Given this list of marker genes KLF4 (KLF transcription factor 4), KLF9, RB1, CDH1, STRAP, SP1, FOXA2, FOXP2, ARID1A, FOXJ2, TFAP2A, ZEB2, here is a description of the gene set: Reactome Pathway: Positive Regulation of CDH1 Gene Transcription <p>Numerous transcription factors have been identified as direct positive regulators of transcription of CDH1 gene (also known as E-cadherin, epithelial cadherin, Cadherin-1, CADH1, or uvomorulin). Only those transcription factors reported to directly stimulate CDH1 gene transcription in at least two studies have been annotated in this pathway. These include ARID1A, FOXA2, FOXJ2 (Martin de Lara et al. 2008; Zhang et al. 2018), KLF4, KLF9, RB1, SP1, and TFAP2A.</p><p>Transcription factors implicated in direct upregulation of CDH1 gene transcription by a single study are not shown in the pathway diagram. These include CREB1, GATA3, GRHL2, GRHL3, MITF, MSX2, NACC1, PDX1 (Marty Santos et al. 2016), RUNX2, and TFAP2C.</p> part of: Regulation of CDH1 Gene Transcription species: Homo sapiens